Given this list of marker genes FBXL16, TAOK2, TM2D3, PPME1, CAPN15 (calpain 15), NFIC, LARP1, PRCC, ABCG4, NPLOC4, FMNL1, DDX54, USP30, RAP1GAP2, SLC8A2 (NCBI Gene Id 6543), CPNE5, SLC6A17, ADGRA2, KCNC1, CADM3, ACSF3, TMEM222, AKT3, TEX264, TYSND1, EMP2 (epithelial membrane protein 2), PCDHGA1, RUFY4, GNAI2, EFNB3 (ephrin B3), ZDHHC3, CBX7, IRF5, SLC45A2, ESPN, ACE (angiotensin I converting enzyme), FGF19, NMNAT2, TRAF7, ZNF618, EEF2KMT, SLC25A19, ZBTB4, PPIE, SEPSECS, ZFP41, NT5DC3, RAB35, CTCF, SPIB, LIMS4, BCL2L13, TNFAIP1, PRKACA, TRIM62 (NCBI Gene Id 55223), HSPB6, ARID3B, SEMA7A, AOC3, VWA3A, TBL1XR1, PCDHGA8, BTBD9, FOXK1, PARN, ALX4, BHMT2, APLN, SYNJ1, TNC, LY6G5C (NCBI Gene Id 80741), NGFR, PCDHGA3, PEX14, TLX1, NANOS2, NDRG4, FOXP2, P2RY2, TRIM66 (NCBI Gene Id 9866), SLC1A3, ALDH4A1, GIT1, LIMS3, EPHB2 (NCBI Gene Id 50980), NCOR1, ARHGDIA, TMEM54, PKLR (NCBI Gene Id 5313), KIF21B, PAQR4, RAB7A, PRLHR, CBX6, SHB, PKP2, STUM, EIF5, PMM2, ENGASE, GTPBP1 (GTP binding protein 1), OSBP2, NPTX1, BTF3L4, MICB, CABLES1, MECP2, ARRB1, G6PD, SLC9A3, FBXO41, VAMP1, SLC46A1, PCDHGA4, MPZL2, MAPK8IP3, VDR, IQSEC2, GLIS2, PCDHGB5, CYP26B1, SPOCK2, CDR2L, LRP1 (NCBI Gene Id 4035), PAK4, TBC1D16, LZTS1 (leucine zipper tumor suppressor 1), GPBP1L1, PCDHGA7, WDTC1, NECTIN1, PCDHGB1, MGLL, CNP, TMEM41A (NCBI Gene Id 90407), DAG1, RNF20, ITCH, IGSF8, HES6, PCDHGA12, MPRIP, NKAIN2, TMC7, HLA-DOB, RNF44, MARVELD1, SDC3, ZNF385A, ZNF454, CLCF1, CMTM4 (NCBI Gene Id 146223), CRTC1 (NCBI Gene Id 94159), UBA1, STRBP, ARHGEF40 (NCBI Gene Id 55701), PPP1R16B, FAM163A, LMF2 (lipase maturation factor 2), HIPK2, MFAP1, GFI1, ZC3H7B, SDK2, NF2, MTCL2, NAP1L3, MID2, WDR48, TCP10L, PCDHGC5, ARHGAP1, NDUFA4L2, GNG13, SH3PXD2B, NMD3, NCLN, SEMA6A, YY1AP1, NKIRAS2, NFASC, PLEC, BRAT1, DCAF7, PCDHGA10, FOSL1, PIK3R6, NDUFA11, ACVR1B, PACS1, CLDN19, LIFR, TRABD2B, PSME3IP1, ZDHHC22, PYGM (glycogen phosphorylase, muscle associated), TOM1L2, SYT12, FAM170B, AP5B1, TTYH3, ATP2B2 (NCBI Gene Id 491), ZNF594, PPM1M, PKM, TMEM127, ZNF609, SH3PXD2A, TJAP1, EEFSEC, PRAF2, CPLX2, TMCC3, PML, SYNDIG1L, TRAF1 (TNF receptor associated factor 1), ASB6, SYT7, TOX2, OTOF, TRAM2, SPRN, SDK1, SLC35F5, CYB5R3, CINP, SLC35E4, TXLNG, ARMC3, SNX19, PCDHGB3, PTCD1, PDE4D, SLCO3A1, COL1A1, RELT, CERS1, CLIP2 (NCBI Gene Id 84805), TTLL6, COPS7B, ZNF395, PAX7 (NCBI Gene Id 5081), TRMT61A, PCDHGB2, VSIR, STK40, TRAPPC9, KREMEN1, PPM1F, ST3GAL1, BRD3, GSK3A, LOXL3, LHX3, AKT1S1, SUFU (NCBI Gene Id 51684), PLXNA4, SAMD4B, WARS1, CLCN5, ABCF2, PLXNA1, GRM2, RIMS4, SLC2A8, ACVRL1, PRDM11, CEP85, BCAM, SCRT1, SLC37A2, HCFC1, CDC42SE1 (CDC42 small effector 1), PPM1H, MEN1, KLK4, PCDHGA9, TBC1D5, SARM1, OGG1, EDAR, DENND2B, PCDHGA11, MDGA1, CLDN18, NAT8L, JMJD8, PLXDC2, MRAS, FAM240A, NFIX, RPIA, DIAPH1, PPP1R11, ARHGAP4, CELF3, SMPD3, MBTD1, CPEB3, TXLNA, ZNF219, COX10, CLIP3, IGFBP5, TPD52L1, NKD1, PCDHGA5, MAP6D1 (NCBI Gene Id 79929), PPIL2, KCNIP3, ABCF1, TAGLN, OLFML2A (NCBI Gene Id 169611), LRRC4B, ABR, SLC39A3, PHLDB1, RAB5A, ATP5MF-PTCD1, SUV39H1, DNAJB5, RPL28, GRIK3, PTPRF, RASD2, TMEM151B, PPP3R2, FBXL18, CDK18, TMEM178B, SLK, MYL12A, ADGRL1, METRN, CLDND1, ZFR2, RAB6B, PCDHGB6, FBXO31, DNM1, MOCS1, ADGRG3, PCDHGC3, CENPP, PRCD, PKIG, STRA6, NCS1 (neuronal calcium sensor 1), CX3CL1, WHRN, NCSTN, BARHL1, GPRIN1, SMYD5, PARVG, SZT2, CUEDC1, DCANP1, ZNF672, EVC (NCBI Gene Id 7886), FAM219A, ARNT2, PCDHGC4, HOXA7, KIAA0930, CPLX3, CLCNKB, ACTMAP, NR2C2 (NCBI Gene Id 7182), CRAMP1, ENG, ERC1, ARMC9, GAB1, PCDHGB4, SAMD11, DUSP8, JPH3, TTL, REXO1, SRD5A1, PCDHGA2, MYO1C, GIPC3, HOXA11, CHD5, NAA60, ZMIZ1, ZNF346, SON, JADE2, TRPM3, CHRNA4, CPTP, PCDHGA6, CDYL2, CPSF7, APC2, SLC12A4, KIAA0513, CASP10, ARC, RNF38, KCNS1, FSTL3, CPNE2, MRTO4, CABP7, MAPKAPK3, SRSF7, NATD1, ARL2BP, PCDHGB7, CNIH2, TXN2, FAIM2, here is a description of the gene set: from publication Chen Y, Wang X (PMID 31504780) species: Homo sapiens Genes predicted to be targets of miRBase v22 microRNA hsa-miR-4492 in miRDB v6.0 with MirTarget v4 prediction scores > 80 (high confidence targets). Human Gene Set: MIR4492